The following is a description of a gene set: Any process that modulates the frequency, rate or extent of protein maturation. studied in species Homo sapiens Human Gene Set: GOBP_REGULATION_OF_PROTEIN_MATURATION, and this is the list of marker genes: RHBDD1, SRC, RASAL2, PRSS37, LDLRAD3, TMEM98, CHAC1, S100A10, PLAU, ACP4, NKD2, FURIN, ANXA2, FGA, SERPINE1, CLN3, HPN, MYH9, MAGEA3, RUNX1, RFX4, PRKACB, INPP5B, ENO1, SNX12, RNF139, ADAM8, CWH43, PLAT, PRKACA, GAS1, TFR2, GLG1 (golgi glycoprotein 1), THBS1, CCBE1, NLRC4, GSN (gelsolin), CLEC3B, SIRT4, F12, MMP14, RPS6KA2, MDM2, ASTL, USP17L2, NLRP7, CDK20 (NCBI Gene Id 23552), SPON1, KLKB1, TNP1, IL1R2, PLAUR, IFT52, TNP2, SERPINF2, ANGPTL8, AKT1, CNTN2, SERPINE2, MELTF, LRRK2, MIR152, BAG2, CTSZ, PLGRKT, PRNP